The following is a description of a gene set: Immune infiltration in pancreatic cancer Human Gene Set: WP_IMMUNE_INFILTRATION_IN_PANCREATIC_CANCER studied in species Homo sapiens, and this is the list of marker genes: CCL20, REG4 (regenerating family member 4), CSF2, IL5, IL12B, VEGFD, IL4, LGALS3, TGFB1, IL1B (interleukin 1 beta), IL17A, IL17F, LGALS9, IL17D, IL17B, CXCL8, CCL5, IFNG, MMP9, CXCL1 (C-X-C motif chemokine ligand 1), IL25, TNF, VEGFB, IL13, LGALS1, IL17C, TGFB2, CXCL5, CCL28, IL12A, IL23A, CXCL12, CCL2, IL6, TGFB3, VEGFC, VEGFA, IL2, IL10